Given this list of marker genes PPP2R5D, PPP2R1B, PPP2CB, PPP3CC, PPP1CA, PRKACA, PRKAR1B, PRKAR1A (NCBI Gene Id 5573), PPP3CB, PRKAR2B, PRKACG, PDE4C, PPP1R1B, PPP2R1A, PPP3CA (protein phosphatase 3 catalytic subunit alpha), CALM1, PRKAR2A (protein kinase cAMP-dependent type II regulatory subunit alpha), PPP3R1, PDE4A, CDK5, PPP2CA, PDE4D, PDE4B, PRKACB, here is a description of the gene set: studied in species Homo sapiens part of: Opioid Signalling Reactome Pathway: DARPP-32 events Dopamine- and cAMP-regulated phosphoprotein, Mr 32 kDa (DARPP-32), was identified as a major target for dopamine and protein kinase A (PKA) in striatum. Recent advances now indicate that regulation DARPP-32 phosphorylation provides a mechanism for integrating information arriving at dopaminoceptive neurons, in multiple brain regions, via a variety of neurotransmitters, neuromodulators, neuropeptides, and steroid hormones. Activation of PKA or PKG stimulates DARPP-32 phosphorylation at Thr34, converting DARPP-32 into a potent inhibitor of protein phosphatase-1 (PP-1). DARPP-32 is also phosphorylated at Thr75 by Cdk5, converting DARPP-32 into an inhibitor of PKA. Thus, DARPP-32 has the unique property of being a dual-function protein, acting either as an inhibitor of PP-1 or of PKA.